The following is a description of a gene set: from publication Nakaya HI, Wrammert J, Lee EK, Racioppi L, Marie-Kunze S, Haining WN, Means AR, Kasturi SP, Khan N, Li GM, McCausland M, Kanchan V, Kokko KE, Li S, Elbein R, Mehta AK, Aderem A, Subbarao K, Ahmed R, Pulendran B (PMID 21743478) species: Homo sapiens Systems vaccinology has emerged as an interdisciplinary field that combines systems wide measurements and network and predictive modeling applied to vaccinology. Here we used the systems vaccinology approach to study the molecular mechanisms underlying th Human Gene Set: GSE29618_BCELL_VS_PDC_DAY7_FLU_VACCINE_DN Genes down-regulated in comparison of B cells from influenza vaccinee at day 7 post-vaccination versus plasmacytoid dendritic cells (pDC) at day 7 post-vaccination., and this is the list of marker genes: SERPINF1, SERTAD2, SSR3, OFD1, PIK3CG, SLC20A1, NAGA, ATG101, LILRB4, AHCY, TCF4, ENPP2, LAMP5, DSTN, GPM6B, POLB, SIDT1, GSN, BCAP31, NUCB2, TLR7, PTMS, PAFAH2, CRYM, TYROBP, SRP14, PARK7, IMPA2, ALDH2, DUSP3, NECTIN1, SOX4, GRAMD1B, HERC5, SMPD3, IL18R1, SEC61A2, KCNK10, GNAQ, CERS6, CD2AP, MARCHF2, STMN1, ZNF589, OTULINL, FCER1G, LHFPL2, TPM2, RNF130, CDK2AP2, FCER1A, APP, HEXB, FCGRT, CLCN5, NOTCH4, AHNAK2, TNFRSF21, HYOU1 (NCBI Gene Id 10525), MYL12A, PTGDS, LILRA4 (NCBI Gene Id 23547), KRT5, TMEM8B, CD68, PHEX, FKBP2, ICAM1, CTSC, SLC39A6, CCDC186, GFI1, MAP2K6, PPP1R14B, JAG1, GAS6, CUEDC1, AEBP1, ATP2B4, SFT2D2, TMEM109, UGCG (UDP-glucose ceramide glucosyltransferase), TEX2, FHL1, CCR2, BAHCC1, MYDGF, DAB2, NREP, MAP1A, CD302, DAPK1, DPP4, FLT3, GNA15, MYB, DUSP5, LAPTM4A, CUX2, GPX1, MAPKAPK3, GSTP1 (NCBI Gene Id 2950), EPHB1, ST14, CST3, SCARB2, EIF4A3, NDRG1, TRIT1, RUNX2, GRSF1, SCAMP5 (NCBI Gene Id 192683), SLC7A11, IRF8, SLC1A5, PTPRE, TMED3, EGLN3, IRF7, IL3RA, STT3A, PSAP, MYCL, TMED10 (transmembrane p24 trafficking protein 10), DNAJC4, PGD, CSF2RB, MACROH2A1, SIVA1, DST, PMP22, CORO1C, ST3GAL2, TXN, ITM2C, MDFIC (NCBI Gene Id 29969), CRYBG3, SEMA3C, ZDHHC17 (NCBI Gene Id 23390), SH3BP4, RPS6KA3, GUCY1A1, CBX6, DAD1, TBC1D4, SCN9A, DHRS7, MAN2B1, FLNB (NCBI Gene Id 8413), NPC1, MGAT4A, SEC61B, DACH1, SLC7A5, SCT, GRN, GZMB, ALOX5AP, KIAA0513, PTPRS, RPS6KA4, LEPROT, CD4, LILRB1, CD164, GPR171, PON2, DNASE1L3, SHTN1, AHI1, KCNA5, MCC (MCC regulator of WNT signaling pathway), CRIM1, MAPKAPK2, LAIR1, IDH3A, OBSL1, MAN1A1, ST6GALNAC4, MGST2 (NCBI Gene Id 4258), ATP10A, NRP1, HIGD1A, RRBP1, PTBP3, ADA, LDLRAD4, RNF5, SPCS1, SORT1, TGFBI, PHB1, DCK, MEF2D, IQGAP2, TRAF4, RAB15, CAPRIN1